The following is a description of a gene set: from publication Chen Y, Wang X (PMID 31504780) Mouse Gene Set: MIR_3090_5P Genes predicted to be targets of miRBase v22 microRNA mmu_miR_3090_5p in miRDB v6.0 with MirTarget v4 prediction scores > 80 (high confidence targets). studied in species Mus musculus, and this is the list of marker genes: Zfp628, Elovl2, Tppp3, Cd53, Tuft1, Elapor1 (endosome-lysosome associated apoptosis and autophagy regulator 1), Cbln3, Fhod1 (formin homology 2 domain containing 1), Ppcdc, Dner, Gab1, Lgalsl, Zbtb26, Celsr3, Heyl, Tspan18, Zbtb44, Fgf12, Dynlt1a, Aak1, Smg6, Cmc1, Grm5, Dynlt1f, Rere, Hacd4, Scn4b, Hs3st3a1, Klhl34, Dars2, Ptp4a2, Dnmt3a, Map1a (NCBI Gene Id 99114), Serf2, Rbfox1, Zfp704, Dynlt5 (NCBI Gene Id 67344), Tmem140, Zfp655, Asah2, Plekhb2, Slamf7, Zscan29, Oit3, Nlk, Ctnna3, Slc25a31, Zhx3, Rbms3, Gnpnat1, Opcml, Tafa1, Tpbgl (NCBI Gene Id 245190), Cpeb2, Eif2ak2, Shisal1, Zfp109, Tmem170, Cacnb2, Golim4, Mid1, Cdyl2, Caskin1, Tex264, Kcnab1, Sh3gl2, Fam118b, Carnmt1, Syne3, Marcks, Mettl4, Dnajc7 (NCBI Gene Id 67633), Smc3, Nherf2, Uba2, Mtcl2, Has3, Ptpn2, Zfp942, Cdc42se2, Zfp945, Syt5, Neurl1a, Krt71, Zfp11, Slc24a2